The following is a description of a gene set: Formation of an anuclear keratin layer Orthokeratosis species: Homo sapiens Human Gene Set: HP_ORTHOKERATOSIS, and this is the list of marker genes: CARD14, NIPAL4, DSG1, ENPP1 (ectonucleotide pyrophosphatase/phosphodiesterase 1), FLG2, CSTA, CERS3 (ceramide synthase 3), COL14A1, KDF1, AAGAB, GJA1, NSDHL, WNT10A, LIPN, LORICRIN, KRT10, TRPV3, CLDN1 (claudin 1), CYP4F22, KRT1